The following is a description of a gene set: This event has been computationally inferred from an event that has been demonstrated in another species.<p>The inference is based on the homology mapping from PANTHER. Briefly, reactions for which all involved PhysicalEntities (in input, output and catalyst) have a mapped orthologue/paralogue (for complexes at least 75% of components must have a mapping) are inferred to the other species. part of: Signaling by Interleukins electronically inferred by orthology from the curated human pathway species: Mus musculus Reactome Pathway: Interleukin-1 family signaling, and this is the list of marker genes: Nfkb2, Psmd13, Il18bp, Psma1, Psma3, Myd88, Hmgb1, Nfkbib, Map2k6, Psmc3, Psma7, Il18rap, Nlrc5, Psmb7, Psmb4, Sqstm1, Lrrc14, Ikbkb, Ube2v1, Psmc4, Irak1, Il36b, Psmd6, Psmc5 (NCBI Gene Id 19184), Psma4, Psma2, Psmb6, Casp8, Il1r1, Psmd12, Psma6, Ager, Cul1, Psmd7, Psmc6, Rela, Nfkb1, Peli2, Psmc2, Map3k8, Il1r2, Ubb, Mapk8, Nkiras1, Psma5, Tab3, Ctsg, Il33, Nlrx1, Il1f10, Rps27a, Tab2 (TGF-beta activated kinase 1/MAP3K7 binding protein 2), S100b, Ube2n, Il18r1, Psmb5, Il1rl1, Tab1, Nfkbia, Tifa, Il1a, Irak3, Psmc1, Il36a, Psmd1, Gsdmd, Map3k3, Casp1